The following is a description of a gene set: The activation signaling of transcription factor nuclear factor-kB (NF-kB) plays central role for immune system. One of key kinase mediating this pathway is TAK1 in adaptive and innate immunity. However, role of TAK1 in B cell receptor signaling is still unclear. To know effects of TAK1-deletion on the gene expression induced by anti-IgM, we performed the time course analysis in comparison of wild type with TAK1-deleted splenic B cells. from publication Shinohara H, Behar M, Inoue K, Hiroshima M, Yasuda T, Nagashima T, Kimura S, Sanjo H, Maeda S, Yumoto N, Ki S, Akira S, Sako Y, Hoffmann A, Kurosaki T, Okada-Hatakeyama M (PMID 24833394) Genes down-regulated in B lymphocytes treated by anti IgM for 3h: wildtype versus MAP3K7 knockout. Human Gene Set: GSE41176_WT_VS_TAK1_KO_ANTI_IGM_STIM_BCELL_3H_DN studied in species Homo sapiens, and this is the list of marker genes: CDK4, GGCT, PSMD11, ATP6AP1, NSMAF, HNRNPA3, DNAJC7, IL2RG, IGSF6, GOLGA3, LIMS1, CCL7 (C-C motif chemokine ligand 7), MRPL23, SLC16A6, MYDGF, HES1, EWSR1, RNH1, CD47, GNPDA1, ALOX5AP, GSR, ZFYVE26, TSR1, HDGF, AKR1B1, SQSTM1, CALU, NRAS, ATP6V1F, DPH2, CPVL, PES1, MAP3K4, MAPK6, CSTB, LPL, UBE2J1 (ubiquitin conjugating enzyme E2 J1), CD63, LRRC41, SPP1, PLOD3, GTPBP6, CCR1, SRM (spermidine synthase), S100A11, RDX, NPC1, DUSP3, URM1, RGL1, TRMT1, TOMM40, NBN, SPINK1 (serine peptidase inhibitor Kazal type 1), ATP5MC1, ABCE1, EIF4E, PSMD8, IGF2R, CCRL2, NME1, ATP2C1, INHBA, MFSD5, DDX39A, POLR1C (NCBI Gene Id 9533), TNFSF14, NR3C1, EBNA1BP2, GYPC, GSTO1, RAD23B (NCBI Gene Id 5887), BYSL, TBC1D9, TDP2, HK2, EIF2S1, IQGAP2, DKC1, PDIA6, GEM, CYBA, HDDC2, CD93, SEC24C, CRIM1, ST3GAL6, DYRK3, ANXA2, PISD, PUM3, AK4, HIP1, HSPA9, BATF, SERPINA1, UPP1, RELA, PTAFR, TIMM17A, MSC, MAK16, CCR5, MRPS12, LYSET, DDX10, STT3A, FKBP2, BCAT1, HEXA, ATP6V1H, LTBR, BCL2L1, STX4, GBA1 (glucosylceramidase beta 1), METTL1, CTNS, SRSF1, TNFRSF8, BHLHE40, PIR, PLEKHB2, IRAK1, LSP1, CSF2RA, MET, BANF1, HSPE1, COMT, PPIB, EXOSC7, TPP1, GPSM3, EMG1, GLA, MAD1L1, CSF2, OSM, EIF3B, HYOU1, RAB13, CLUH, KEAP1, GRN, M6PR, MRPL12, CAPG, SLC38A6, MPV17, PSMD3, NUP188, FUBP1, SRSF3, BET1, RRN3P1 (RRN3 pseudogene 1), EIF4G1 (eukaryotic translation initiation factor 4 gamma 1), ADAMDEC1, MAT2A, FERMT2, TARDBP, RENBP, RAD23A, HNRNPU, RNASEH1, TNFRSF14, DDX27, PTPN6, RAB33A (NCBI Gene Id 9363), WDR18, UTP3, RIPOR2, HSP90B1, S100P, VPS11, GSAP, CYP1B1, CEBPB, BOLA2, WSB2, URB2, IFRD2, LMNB2, LHFPL2, IL1RN, NHP2, TFEC, RBM19, MGAM, BCAP31, S100A9, GSDME, DENND4B, CLN3, CEP170, CTSD, RRAGD, PHACTR1, NOL7, JMJD6